Given this list of marker genes RRBP1, HNRNPA3, AXL, DHX9, POLR2I, POLR2F, HSPA1A, MAPRE3, SYMPK, SNRPB2, H2BC1, DPM2, SNRPB, DNAJB11, H2BC9, POLR2J, NACA, TXNL4A, HNRNPC, H2BC15, SMNDC1, DNAJC8, GPKOW, SNRPA1, OST4, AQR, EIF4A3, SRRT, RBM5, RPS27A, MAGT1, UFD1, H2AC11, H2BC12, CRNKL1, PUF60, EMC4 (ER membrane protein complex subunit 4), H2BC3 (H2B clustered histone 3), SDC2, PABPC1, U2AF1L4, RBMX, UBE2I, HNRNPK, SF3A1, NRBP1, SPCS1, PDIA3, EIF4E, CAMK2D, LYN, STT3B, POLR2L (NCBI Gene Id 5441), SNRNP200, AP2A1, UBA1, NFKBIB, DDX5, C1QA, SNRPD3, SPCS2 (NCBI Gene Id 9789), CLU (NCBI Gene Id 1191), CPSF7, CLDN1, P4HA1, PDCD6IP, SNRPD1, RETREG1, RTN3, BUD31, SNRPD2, SUMO1, SDC4, BAG2 (BAG cochaperone 2), APOA1, CTR9, PQBP1, PIK3R1, U2AF2, UBA7, EIF4G1, SUN2, WDR33 (WD repeat domain 33), H2BC26, DENCMEMSB, PPIL1, P4HA3, CSTF2T, PIK3C3, RBM17, DDX23, HNRNPF, HSPG2, AP2S1, CD14, SRSF9, FIP1L1, ISY1, POLR2H, ATL2, H2BC13, PCF11, TLR4, GBF1, H3C15, DNAJA2 (NCBI Gene Id 9237), H2AC14, RPL18, TJP1, XPO1, STING1, LY6E, H3C1, HDLBP, SPCS3, AP2B1, HNRNPU, NCBP1, EIF4A1, DPM3, HNRNPH1, F2, IFIH1, DDX46, CPSF6, PAPOLA, C4A, H2BC21, LEO1, H2AC25, VTN, SF3B3, GPC4, C4BPB, P4HA2, MTOR, SRSF2, MERTK, POLR2A, TSG101, EIF4A2, UBA52, HNRNPH2 (NCBI Gene Id 3188), TRIM25, SCAP, POLR2E, LY96, SRSF7, VCP, CD209, H2BC18, SRSF6, SNRPF, NCL, SRRM1, PRKG2, SNRPG, CALR, CHERP, H2BC11, NEK2, HNRNPR (heterogeneous nuclear ribonucleoprotein R), PPIL4, DDX42, GRPEL1, PRPF6, GPC2, SF3B2, SNRPE, SF3B1, SNRNP40, CDC5L, SF3B4 (splicing factor 3b subunit 4), SNRPN (NCBI Gene Id 6638), CD2BP2, HSP90AB1, H2AC1, BCAS2, SF3B6, RBM22, COG1 (component of oligomeric golgi complex 1), POLR2B, WBP11, ALYREF (NCBI Gene Id 10189), PRR5, PCBP1, KPNA7, CAMK2A, HNRNPA1, P4HB, POLR2D (RNA polymerase II subunit D), PRPF19, H2AC21, PCBP2, DHX16, DDOST, MAVS, CSTF1, HNRNPL, CAMK2G, EIF4G3, PPIE (NCBI Gene Id 10450), RIPK1 (receptor interacting serine/threonine kinase 1), FUS, KDELR1 (KDEL endoplasmic reticulum protein retention receptor 1), RPN2, HSP90AA1, PPIL6, NPLOC4, UBA6, SDC1, EXOC1 (exocyst complex component 1), CGAS, AP2A2, U2AF1, MLST8, CWC15, EIF4G2, H2AC18, TMEM258, PABPN1, H2AC6, CD33, PTBP1, RBM10, SRRM2, U2SURP, XAB2, PAF1, STT3A, PLRG1, RNPS1, CWC27, CDC40, RPSA (ribosomal protein SA), VIM, XRN1, MAPKAP1, KPNA1, HNRNPA0, KPNA5, UBA5, IKBKE, TAOK1, RICTOR, GPC3, H2BC17, PROS1, SF3A2, DAD1, DPM1, GPC5, AP2M1, ELAVL2, CWC25, HAVCR1, EFTUD2, SRSF5, SNW1, MRC1, SDC3, CSTF3 (cleavage stimulation factor subunit 3), RPN1, NCBP2, RTF1, FASN, DAXX, ELAVL1, H2AC20, YBX1, CLP1, DYNLT1, AGRN, CPSF1, STAT2, CANX, EIF4E3, CSTF2, CTNNB1, MAP1LC3B, HNRNPA2B1, PRPF8, SF3B5, HYOU1, NMT1, KPNA3, MMP9, UBC, OSTC, UBB, PRKG1, SEC11A, PML, NUDT21, H2BC5, SEC11C, H2BC14, IPO7 (NCBI Gene Id 10527), SRSF11, CDC73, RNASEK, CAMK2B, DNAJC10, POLR2G, PPIL3, DNAJC3, DHX15, SF3A3, GAS6, AUP1, H4C1, DDX3X, H2AC7, DHX38, TAL1, SUGP1, CWC22, PRCC, SKIC8, ATG14, TIMD4, FURIN, TUSC3, H2AC12, NFKBIA, CPSF2, HNRNPM, HNRNPD, CCAR1, CLEC5A, ATG7, BTF3, HNRNPUL1, CPSF4, CTNNBL1, CPSF3, TYRO3, H2AC4, UBR4, C4BPA, POLR2K, PIK3R4, SRSF3, RPTOR, KPNA2, KPNA4, CD300A, C4B, BECN1, ACOT2, H2BC4, HSPA5, GTF2F2, SRSF4, GPC1, MBL2 (mannose binding lectin 2), SRSF1, KPNB1, GTF2F1, UBA3, HSPA8, PEX19, GPC6, CLINT1, C1S, POLR2C, PHF5A, HSPA1B, here is a description of the gene set: studied in species Homo sapiens Dengue is a mosquito borne viral infection caused by dengue virus (DENV), a member of the Flaviviridae family, genus Flavivirus. Dengue is the most common arthropod borne viral infection in the world. Infection with DENV can proceed asymptomatically, result in a self limited dengue fever, or cause a more severe illness in the form of dengue hemorrhagic fever and dengue shock syndrome (DHF, DSS; reviewed in Rodenhuis-Zybert et al., 2010). Four distinct serotypes of DENV exist (DENV1-4), and acquired immunity is serotype-specific. Secondary infection with a heterologous serotype or primary infection in infants born to dengue-immune mothers are risk factors for developing dengue hemorrhagic fever and dengue shock syndrome, due to antibody-enhanced infectivity.<br><br>Like other Flaviviridae, DENV is an enveloped, positive-sense RNA (+ssRNA) virus. Mature dengue virions contain genomic +ssRNA and three structural proteins, C, M, and E. Protein C is the capsid protein which encapsulates genomic +ssRNA, forming the ribonucleocapsid. In cases where no direct experimental evidence pertaining to Dengue virus 2 Thailand/16681/84 strain was available, viral life cycle events were manually inferred from related dengue strains, as indicated. part of: Viral Infection Pathways Reactome Pathway: Dengue Virus Infection